The following is a description of a gene set: Catalysis of the transfer of a galactose residue from a donor molecule to an oligosaccharide, forming a beta-1,3-linkage. studied in species Mus musculus Mouse Gene Set: GOMF_BETA_1_3_GALACTOSYLTRANSFERASE_ACTIVITY, and this is the list of marker genes: B3galt5, C1galt1, B3galt4, B3galt2, C1galt1c1, B3galnt1, B3galt1